Given this list of marker genes Galnt14, Arxes1, Spock2, Dcbld1, Rab27a, Soat1, Ppid, Adcy7, Ldlr, Tead4, Ano1, Tmem108, Tuba8, Col4a3, Pcbp3, Slc35e3, Txnrd3, Slc7a7, Parp3, Slco3a1, Gipc2, Muc1, Idi1, Cldn18, Fdps, Slco4c1, Tspan11, Tspan8, Dusp7, Kcnj15, Cpm, Fzd2, Phactr1, Trpm6, Akap5, Msmo1, Srebf2, Rerg, Insig1, Alad, Abca3 (NCBI Gene Id 69158, ATP-binding cassette, sub-family A member 3), Lamp3, Arhgap45, Mvd, Ackr2, Ctsb, Tekt5 (tektin 5, NCBI Gene Id 70426), Col4a4, Lama3, Camk2b, Chst11, Bspry, Rhof, Slc52a2, Eif5a2 (NCBI Gene Id 83812), Tmod1, Cavin2, Fabp5, Thbs3, Dhcr7, Egfr, Aif1l, Sema3a, Matn4, here is a description of the gene set: studied in species Mus musculus from publication Zhang Y, Goss AM, Cohen ED, Kadzik R, Lepore JJ, Muthukumaraswamy K, Yang J, DeMayo FJ, Whitsett JA, Parmacek MS, Morrisey EE (PMID 18536717) Epithelial organs, including the lung, are known to possess regenerative abilities through activation of endogenous stem cell populations, but the molecular pathways regulating stem cell expansion and regeneration are not well understood. Here we show that Gata6 regulates the temporal appearance and number of bronchioalveolar stem cells (BASCs) in the lung, its absence in Gata6-null lung epithelium leading to the precocious appearance of BASCs and concurrent loss in epithelial differentiation. This expansion of BASCs was the result of a pronounced increase in canonical Wnt signaling in lung epithelium upon loss of Gata6. Expression of the noncanonical Wnt receptor Fzd2 was downregulated in Gata6 mutants and increased Fzd2 or decreased beta-catenin expression rescued, in part, the lung epithelial defects in Gata6 mutants. During lung epithelial regeneration, canonical Wnt signaling was activated in the niche containing BASCs and forced activation of Wnt signaling led to a large increase in BASC numbers. Moreover, Gata6 was required for proper lung epithelial regeneration, and postnatal loss of Gata6 led to increased BASC expansion and decreased differentiation. Together, these data demonstrate that Gata6-regulated Wnt signaling controls the balance between progenitor expansion and epithelial differentiation required for both lung development and regeneration. Mouse Gene Set: ZHANG_GATA6_TARGETS_DN Genes down-regulated after cre-lox knockout of GATA6 in airway epithelium.